The following is a description of a gene set: The joining of the lipid bilayer membrane around a vesicle to the lipid bilayer membrane around the Golgi. Mouse Gene Set: GOBP_VESICLE_FUSION_WITH_GOLGI_APPARATUS species: Mus musculus, and this is the list of marker genes: Yipf4, Bet1, Vti1a, Uso1, Yipf7, Vti1b, Stx5a, Yipf5, Sec22b